The following is a description of a gene set: studied in species Homo sapiens Human Gene Set: GOBP_DETERMINATION_OF_DIGESTIVE_TRACT_LEFT_RIGHT_ASYMMETRY Determination of the asymmetric location of various parts of the digestive tract with respect to the left and right halves of the organism. The digestive tract is the anatomical structure through which food passes and is processed., and this is the list of marker genes: CCDC103, CCDC39, DNAAF1, ZIC3, CCDC40, MEGF8, NPHP3